Given this list of marker genes Wnt5b, Nphp3, Vangl2, Lbx2, Dvl1, Zfp568, Dvl2 (dishevelled segment polarity protein 2), Sfrp1, here is a description of the gene set: Mouse Gene Set: GOBP_CONVERGENT_EXTENSION_INVOLVED_IN_GASTRULATION The morphogenetic process in which an epithelium narrows along one axis and lengthens in a perpendicular axis usually resulting in the formation of the three primary germ layers, ectoderm, mesoderm and endoderm. species: Mus musculus